The following is a description of a gene set: This event has been computationally inferred from an event that has been demonstrated in another species.<p>The inference is based on the homology mapping from PANTHER. Briefly, reactions for which all involved PhysicalEntities (in input, output and catalyst) have a mapped orthologue/paralogue (for complexes at least 75% of components must have a mapping) are inferred to the other species. electronically inferred by orthology from the curated human pathway Reactome Pathway: Transport of glycerol from adipocytes to the liver by Aquaporins species: Mus musculus part of: Aquaporin-mediated transport, and this is the list of marker genes: Aqp7